Given this list of marker genes LBX1 (NCBI Gene Id 10660), STYK1, PHF20, PEA15, PRDM9, DCTN6 (NCBI Gene Id 10671), GGPS1, ZPBP, ATF1, LTN1, NSUN3, S100A7, AFM, ALPK3, ZNF212, ADAP2, DPM1, KIN, ANO2, ZFYVE16, TREM1, ARNT2, ANAPC10, CSGALNACT1, SAR1B, PSMD10, DEFB4A, SPTLC2, TRHR, SAT1, NCK1, MYH7B, PTGS2, UBE2V2, SLC30A9 (solute carrier family 30 member 9), BIK, LINC01587, SPRR2B, ELAVL2, WFDC8, VHL, SLC11A2, ANKRD40, DACH1, LAMTOR3, RLIG1, CRYM, SLC16A3, SEMA3B, TNFAIP6, SLC17A2, MAFF, KCNV1, ZC3H12A, ITGAX (integrin subunit alpha X), CEP76, SNX16, CYP3A43, CAPZA2, TUBD1, ZBTB32, MREG, KALRN (NCBI Gene Id 8997), SDCBP, CCNC (NCBI Gene Id 892), PPP2R3C, CES3, PEAK1, ESM1, ZNF184, GK, GPR25, PIGH, CKLF, RPP30 (NCBI Gene Id 283012), TNFAIP8, PEX6, RHCG, XRCC4, C21orf91, CEACAM7, MOSPD1, LMAN1, HCCS, GNG13 (NCBI Gene Id 51764), PDZD7, SPRY4, FRK, DUOX2, ADRA1D, PLS1, PDCD10, OCM2, KCNS3, EN2, HS3ST1, PTGIS, HSPA13, LMX1B, IL1B, OLFML2B, SFRP4, CCN3, TMEM51, SEPTIN7, TTC33, NKX2-2, FERRY3, PROM1, SERPINB4, CENPQ, NR4A2, ABHD5, PDE8A, NAMPT, GOLT1B, PMAIP1, ARL1, MON1B, RAB40C, SLC17A5, RPAP3, STX7, ERBB4, CAV3, DLGAP1, BZW1 (NCBI Gene Id 9689), SAA4, NDNF, TMPRSS11D, RAPGEF5 (Rap guanine nucleotide exchange factor 5), PI15, KRT86, MED24, PCID2, UBE2E1, ZFAND6, LINC00588, HS3ST3B1, MOB4, EXOSC8, DHFRP3, CCNH, ACTL7B (actin like 7B), CNIH4, CCN6, SUV39H2, AHCYL2, N4BP1, TMOD3, CHEK2, DDN, MRPL33, PPM1B (protein phosphatase, Mg2+/Mn2+ dependent 1B), CHMP4A, BLZF1 (basic leucine zipper nuclear factor 1), SNRPB2, IL4, ATF2, TRAV12-2, COX17, ENOPH1, MYL12A, RPRD1A, FNDC3B, RIT1, ANO3, SPAG4, PYGO1, CARTPT, TMED7, CNIH1, EPYC (NCBI Gene Id 1833), PLOD2, PEX2, CTBS, UGP2, CRTAM, SOX15, LYRM1, C1orf35, PHF10, PARM1, NLGN1, IL17A, SNRNP27, LRRC75B, CYRIB, IL36G, TEX30, TULP2, QPCT, MAP7, CMAS, COL9A2, CETN3, SLC30A6, RWDD3, RAB8B, here is a description of the gene set: Human Gene Set: GSE18281_SUBCAPSULAR_VS_PERIMEDULLARY_CORTICAL_REGION_OF_THYMUS_DN Interaction of hematopoietic progenitors with the thymic stromal microenvironment induces them to proliferate, adopt the T cell fate, and asymmetrically diverge into multiple T lineages. Progenitors at various developmental stages are stratified among different regions of the thymus, implying that the corresponding microenvironments differ from one another, and provide unique sets of signals to progenitors migrating between them. The nature of these differences remains undefined. Here we use novel physical and computational approaches to characterize these stromal subregions, distinguishing gene expression in microdissected tissues from that of their lymphoid constituents. Using this approach, we comprehensively map gene expression in functionally distinct stromal microenvironments, and identify clusters of genes that define each region. Quite unexpectedly, we find that the central cortex lacks distinctive features of its own, and instead appears to function by sequestering unique microenvironments found at the cortical extremities, and modulating the relative proximity of progenitors moving between them. from publication Griffith AV, Fallahi M, Nakase H, Gosink M, Young B, Petrie HT (PMID 20064453) studied in species Homo sapiens Genes down-regulated in thymus cortical regions: subcapsular versus perimedullary.